The following is a description of a gene set: studied in species Mus musculus from publication Chen Y, Wang X (PMID 31504780) Mouse Gene Set: MIR_7046_5P Genes predicted to be targets of miRBase v22 microRNA mmu_miR_7046_5p in miRDB v6.0 with MirTarget v4 prediction scores > 80 (high confidence targets)., and this is the list of marker genes: Plaa, Inava, Chst4, Gfra2, Denr, Erv3, Zfp738, Atp6v1b2, Ppt1, Pcmtd2, Ebf3, Pank3, Zfp386, Slc7a8, Zfp1008, Yod1, Zfp935, Ints2, Prr14l, Kcnk6, Abcb1b, Cpeb2, Tes (testin LIM domain protein), Srpx2, Xpnpep2, Zfp661, Mtap, Nlgn3, Prtg, Zfp729a, Clec3a, Slc24a2 (NCBI Gene Id 76376), Cldn1